Given this list of marker genes Rasd1, Echs1, Clock, Ptges2, Mrpl34, Uqcr11, Taldo1, Xbp1, Etfb, Uqcrh, Cyc1, Abhd5, Rreb1, Psma1, Pdia6, Pcx, Dnajb9, Tysnd1, Myorg, Mknk2, Tomm40, Fabp4 (NCBI Gene Id 16804), Gm27021, Atl2, Fabp5, Sipa1, Grpel1, Cox6a1, Lpin1, Atp5mk, Ptcd3, Esrra, Aco2, Igf2, Ginm1 (glycoprotein integral membrane 1), Pla2g12a, Cbr3, Sdhd, Rgcc, Rpp14, Aifm1, G6pdx, Mrpl18, Cox17, Pparg, Ivd, Bcl2l13, Mrps26, Ormdl3, Gk, Gphn, Gucd1, Mgst3, Gpi1, Cavin1 (NCBI Gene Id 69669), Jagn1 (jagunal homolog 1), Prelid3b, Mrpl12, Prdx3, Crat, Bcap31, Cebpa, Rmdn3, Pex11a, Por, Prps1, Mrpl20, Isca2, Timm23, Ak2, Ndufa8, Mdh2, Acsl1 (acyl-CoA synthetase long-chain family member 1), Fdx1, Sorbs1, Pex14, H3c13, Timm9, Rmc1, Slc5a6, Nrip1, Adam12, Acadm, Gys1, Mrps34, Phb2, Gnpat, Ifngr1, Mtx2, Wfdc21, Slc1a5, Mapk6, Scp2-ps2, Psma5, Mpc2, Ndufb10, Lman2, Timm8a1, Chp1 (calcineurin-like EF hand protein 1), Cycs, Mrpl15, Ndufab1, Ppif, Timm17a, Pim3 (NCBI Gene Id 50885), Aldoa, Pradc1, H2bc13, Dbi, C3, Hk2, Tmem97, Phb1, Cisd1 (CDGSH iron sulfur domain 1), Tbl2, Ppa1, Tob1, Miga2, Coq9, here is a description of the gene set: During cellular differentiation and development, it is recognized that many complex molecular mechanisms as well as precise patterns of differentially expressed genes occur in directing precursor cells toward a given lineage. Using microarray-based technology, we examined gene expression across the course of 3T3-L1 adipocyte differentiation. Total cellular RNA was isolated at times 0, 2, 8, 16, 24, 48, and 96 h following treatment with either standard hormonal inducers of differentiation; insulin, dexamethasone, isobutylmethylxanthine (IDX), or IDX plus trichostatin A (TsA), a histone deacetylase inhibitor and potent adipogenic inhibitor. cRNA was synthesized from cellular RNA and hybridized to high density Affymetrix MG_U74Av2 microarray gene chips containing 12,488 cDNA/Expressed Sequence Tags (ESTs) probe sets. From the IDX-only treated cells, all probe sets that were either unchanged or differentially expressed less than 2-fold throughout differentiation with respect to time 0 preadipocytes were excluded from further analyses. This selection resulted in a net of 1686 transcripts, 859 were increased in expression, and 827 were decreased in expression at least 2-fold across differentiation. To focus in on genes that were more specific to differentiation, the same analysis was performed on IDX plus TsA-treated non-differentiating cells and all probe sets from the IDX-only group that exhibited similar expression profiles in the non-differentiating TsA-treated group were excluded leaving a total of 1016 transcripts that were regulated only under differentiating conditions. Six hundred and thirty-six of these transcripts were elevated at least 2-fold and 380 exhibited a decrease in expression relative to time 0 preadipocytes. This group of genes was further analyzed using hierarchical clustering and self-organizing maps and resulted in the identification of numerous genes not previously known to be regulated during adipocyte differentiation. Many of these genes may well represent novel adipogenic mediators and markers of adipogenesis. from publication Burton GR, Nagarajan R, Peterson CA, McGehee RE Jr (PMID 15033539) Up-regulated at 48-96 h during differentiation of 3T3-L1 cells (fibroblast) into adipocytes. Mouse Gene Set: BURTON_ADIPOGENESIS_5 species: Mus musculus